The following is a description of a gene set: The process whose specific outcome is the progression of the anterior part of the head over time, from its formation to the mature structure. Mouse Gene Set: GOBP_ANTERIOR_HEAD_DEVELOPMENT studied in species Mus musculus, and this is the list of marker genes: Arsb, Col2a1 (NCBI Gene Id 12824), Pfas, Sox9, Lhx1, Bmp5, Ddx10, Ssbp3